Given this list of marker genes SLCO2A1, here is a description of the gene set: Reactome Pathway: Defective SLCO2A1 causes primary, autosomal recessive hypertrophic osteoarthropathy 2 (PHOAR2) part of: SLC transporter disorders species: Homo sapiens The human gene SLCO2A1 encodes prostaglandin transporter PGT. It is ubiquitously expressed and can transport the protaglandins PGD2, PGE1, PGE2 and PGF2A. This transport may be important for release of newly-formed prostaglandins (PGs) and/or their clearance of prostaglandins from the circulation. Defects in SLCO2A1 can cause hypertrophic osteoarthropathy, primary, autosomal recessive, 2 (PHOAR2; MIM:614441), a rare genodermatosis characterised by pachydermia, digital clubbing, periostosis and affecting more males than females.